The following is a description of a gene set: Catabolic peptidases. studied in species Homo sapiens Human Gene Set: MODULE_209, and this is the list of marker genes: KLK10, MMP2, PLA2G2A (phospholipase A2 group IIA), CAPN5, BMP1, F2, PLA2G7, CPA3, CASP4, FAP, CFB, BAAT, SORD, MMP7, PLCG2, ANPEP, ACOX2, CPM, CTSS, ADAM9, PLG, APOC2, CELA3A, GZMK, ENPEP, CAPN2, PRSS2, PLAU, OLR1, C1S, GALE, SERPINB2, AEBP1, PRSS8, PGC, C1R, FURIN, CASP1, CTSK, HMGCS1, PEPD, MMP12, XPNPEP1, F10, HP, LIPC, HPN, UBD, MST1, MMP3, MMP9, CPN1, GZMA, NAPSA, APOC3, LYZ, APOC1, PSMB9, TIMP1, SERPINE1, CTSE, WFDC2, CTSC, PRDX6, PRSS23, CTSL, PROC, PLGLB2, LIPA, TPSAB1 (tryptase alpha/beta 1), GALT, HMGCS2, F12, C2, MMP14, ACE, PROZ, CFI, MMP1, CPB2, IGF1, CTSO, LGMN, MMP13, GZMB, TMPRSS2, PLAT, LAP3, NEDD8 (NEDD8 ubiquitin like modifier)